The following is a description of a gene set: The cell cycle process in which a cell progresses from metaphase to anaphase as part of meiosis. species: Mus musculus Mouse Gene Set: GOBP_METAPHASE_ANAPHASE_TRANSITION_OF_MEIOTIC_CELL_CYCLE, and this is the list of marker genes: Chfr, Mos, Knl1, Ttk (NCBI Gene Id 22137), Cdc20, Mapk15, Zwint